Given this list of marker genes Lamc1, Abcg1, Tgm2, Fam133b, Nfib, Parg, Ist1, Tbr1, Zc3h4, Rnd3, Nalcn (NCBI Gene Id 338370), Nufip2, Cyp4a12b, Pou3f3, Urm1, Ptgr1, Zfp273, Brd1, Plekhf2, Slc38a7, Xndc1, Unc5b, Rbpj, Ube2k, Ncald, Pla2g4c, Ago2, Fbxl20, Dmc1, Tmed4, Adnp2, Arl14epl, Csnk1e, Tmem241, Zfp933, Bahcc1, Cic, Trmt61a, Dcaf7, Elovl2, Vldlr, Ypel1, Foxp2, Fam131a, Ino80d, Erbb4, Ssh2, Cyp4a12a, Serinc5, Zswim4, Mrpl1, Cdyl2 (chromodomain protein, Y chromosome-like 2), Psmd8, 4930453H23Rik, Tlk2, Onecut2, Ccl12, AI593442, Zfp959, Mga, Grm6, Vwa1, Arhgef39, Zbtb41, Crabp1, Mmp2, Vangl1, Lnx2, Hccs, Mat2a, Spag9, Gng2, Rsad1, Taok3, Edem3, St18 (NCBI Gene Id 98640), Kif3b, Lifr, Braf, Dclk1, Wbp1l, A830018L16Rik, Rasgrp4, Aak1, Atad1, Tmem67, Naaladl2, Mycl, Cse1l, Slc16a1, Rfx7, Pde1c, Tbl1xr1 (transducin (beta)-like 1X-linked receptor 1), Foxf1, Scn1a, Nras, Dock3, Agfg1, Kat6a, Perp, Slc18a1, Ube3c, Irx1, Luc7l3, Ptprj, Umad1, Pgr, Pcdh17, Tectb, Lsm11, Fbn1, Ptpru, Crppa, 2410004P03Rik, Hoxb5, Ogfod1, Hnrnpa0, Cltc, Rap2c, Xpo7, Frmd7, St14, Mical2, Kalrn, Papola, Kcna1, Azi2, Rc3h1, Fam78b, Htr1d, Flrt2, Yae1d1, Negr1 (neuronal growth regulator 1), Plagl1, Pin1, Acss3, Zbtb39, B4galt2, Neb, Jazf1 (JAZF zinc finger 1), Shisal1, Creb3l2, Pgr15l, Cnot6l, Dcx, Yy1, Kctd5, Sumo3, Cfap90, Srcin1, Fubp1, Runx1t1, Slc38a9 (NCBI Gene Id 77071), Mat1a, Dlx2, Eif4e2, Ncan, Tet3 (NCBI Gene Id 320786), Etnppl, Cln6, Plagl2, Kcnb1, Dst, Rimklb, Cyp1a2, Igf1, Agtr1b, Thbs1, Ptbp3, Mb21d2, Copz2, Spata2, Slitrk1, Trap1a, Nrcam, Zfp113, Seh1l, Samd4b, Apobr, Prkcg, Pdzd7, Zmym2, Dlgap4, Foxa1, Ppp1r9b, Rtn4, Spred3, Zfp85, Rsrc1, St8sia3, Cul3, Pde12, Slc2a10, Aar2, Lypd6 (NCBI Gene Id 320343), C1qtnf1, Ankrd10, Zfp395, Pecam1, Zdhhc13, Sox4, Zfhx4, Kpna1, Zfx, Tube1, Sema5a, Akap7, G3bp2, Ercc6l, Strip2, Bnc1, Rbmx, Clec12a, Mecp2, Isl1, Kat2a, Dgkk (NCBI Gene Id 331374), Rasef, Exph5, Setd1b, Zbtb4, here is a description of the gene set: studied in species Mus musculus from publication Chen Y, Wang X (PMID 31504780) Mouse Gene Set: MIR_3092_5P Genes predicted to be targets of miRBase v22 microRNA mmu_miR_3092_5p in miRDB v6.0 with MirTarget v4 prediction scores > 80 (high confidence targets).